The following is a description of a gene set: Decreased activity of coagulation factor XIII (also known as fibrin stabilizing factor). Activated Factor XIII cross-links fibrin polymers solidifying the clot. Human Gene Set: HP_REDUCED_FACTOR_XIII_ACTIVITY studied in species Homo sapiens Reduced factor XIII activity, and this is the list of marker genes: F13B, BRAF, SLC37A4, F13A1, PTPN11, MAP2K1